The following is a description of a gene set: Genes up-regulated in comparison of CD8 T cells at 0 h versus those at 72 h after stimulation with IL12. Differentiation of naive CD8 T cells into cytotoxic effector cells requires three distinct signals- antigen (signal 1), costimulation -B7-1 (signal 2) and cytokine, either interleukin-12 or interferon-a/b (signal 3). Interaction of naive CD8 T cells with antigen and B7-1 programs cell division and proliferation whereas the presence of cytokines- IL-12 or IFNa/b promote survival, differentiation and memory establishment. In the absence of signal 3, the cells interacting with antigen/B7-1 undergo tolerance induction. The objective of this study was to elucidate the mechanisms how the provision of signal 3 promotes differentiation and averts tolerance induction in CD8 T cells. Trichostatin A is a pharmacological agent that inhibits histone deacetylase activity, hence regulating chromatin structure and gene expression and differentiation in many cell types. Gene signature profiles of IL-12, IFNa/b and trichostatin A stimulated cells were compared to elucidate the molecular mechanisms of gene regulation. Oligonucleotide microarray analysis is carried out to determine the extent and molecular nature of the CD8 T cell differentiation program induced by IL-12 or IFNa/b in concert with antigen and B7-1 signal. studied in species Homo sapiens Human Gene Set: GSE15930_NAIVE_VS_72H_IN_VITRO_STIM_IL12_CD8_TCELL_UP from publication Agarwal P, Raghavan A, Nandiwada SL, Curtsinger JM, Bohjanen PR, Mueller DL, Mescher MF (PMID 19592655), and this is the list of marker genes: POLR1A, ATP9A, TRAFD1, TLE4, KLF4, CD1D, NRTN, CLTB, N4BP1, HGF, SLC10A3, MTREX, PKD1 (NCBI Gene Id 5310), ZNF326, METTL18, HAO2, RALGPS2, SF3A2, SEC11C, DVL1, SPINK4, NQO1 (NAD(P)H quinone dehydrogenase 1), APP, ZKSCAN1, KLF2, AKIRIN1, TOR1AIP2, IDH3A, CYP3A43, SPR, SUGP2, RAB17, NEDD4L, TNNI2, BSDC1, PAPSS2, C5AR1, RRP9, CWC22, PRPSAP2, PGK2, PITPNA, ADGRG3, SLC25A25, USP21, INSM1, CHPF, KAT2A, PCSK7, NFYC, TCF20, TNNC2 (troponin C2, fast skeletal type), BRWD3, E2F5, LALBA, ZBTB20, GABBR1, CCR9 (NCBI Gene Id 2851), WBP1, FRAT1, SLC39A4, C19orf48P, SLC25A51, GRIA3, NOTCH3, MYL6, RFLNB, ADGRL1, ABCG1 (NCBI Gene Id 9619), SUB1, SARS2, ULK2, CREG1, DUSP12, CTNNAL1, SYT9, METTL1, GIT1, PHB1, RPL12, UCK1, HOXA3 (homeobox A3), DDX24, SIAH1, RPS6KA2, CANT1, NR1D2, CD79B (NCBI Gene Id 974), SPPL2B, DENND2B, LHCGR, RECQL, ICAM2, DALRD3, BPNT1, RAB33B, USP2, TYSND1 (trypsin like peroxisomal matrix peptidase 1), MEOX2 (mesenchyme homeobox 2), SPRTN, EIF2AK2, DFFA, CCDC152, PMPCA, AKAP7, REXO1, PHF1, MAP4K3, TRAF2, POU2AF1, CHMP3, ASGR2 (asialoglycoprotein receptor 2), RAE1, WNT7B, SIN3A, ERCC2, STAT5A, ARF3, SPRYD4, MYOM2, RBM4B, AZI2, BTC, SERPINI1, TIMP2, TLR7, IMPA1, DDX41, GREM2, TMEM115, KRT7, MAP1LC3A, SLC22A1, PPP6R3, KLHL21, STRN4, KERA, VIP, PWP1, CA2, NDUFAF4, UBE2E3, DNAJB4 (DnaJ heat shock protein family (Hsp40) member B4), SOX4, SPSB1, MTFR1L, RCVRN, WDR43, ZPR1, EML5, CEL, PI4K2A, PSAP, SMARCD1, MAP3K3, APOBEC2, DIAPH2, NCOA3, FOSB, PNPO, BLTP2, SLC7A6, GGPS1, LMX1B, PRCC, ARID3B, GZMA, RPL37A, TCEA2, ACKR3, SCMH1, APOBEC1, MBD4, CFI, MCOLN2, DNAJA2, TOMM34, ACTR1B, AP1B1, RETREG2, HYOU1, ADORA1, RECK, FGD3, NFIX, ADRB2, NECAP1, TCN2, DAO, SLFN12, AMMECR1L, SH2B3, DNAJC11, GBF1, MOV10, COL6A2, POLR3D, SH3GL1, MX1, MSL2